The following is a description of a gene set: studied in species Homo sapiens Any process that stops, prevents, or reduces the frequency, rate or extent of a neurophysiological process. Human Gene Set: GOBP_NEGATIVE_REGULATION_OF_NERVOUS_SYSTEM_PROCESS, and this is the list of marker genes: CCN3, MTMR2, HCRT, EIF2AK3, ABCB1, NPY2R, JAM2, FIG4, CTSC, AVPR1A, TAC4, AVP, TNFRSF21, MTNR1B, TMEM98, LPIN1, GLRA1, TNF